The following is a description of a gene set: Preoperative radiotherapy has been widely used to improve local control of disease and to improve survival in the treatment of rectal cancer. However, the response to radiotherapy differs among individual tumors. Our objective here was to identify a set of discriminating genes that can be used for characterization and prediction of response to radiotherapy in rectal cancer. Fifty-two rectal cancer patients who underwent preoperative radiotherapy were studied. Biopsy specimens were obtained from rectal cancer before preoperative radiotherapy. Response to radiotherapy was determined by histopathologic examination of surgically resected specimens and classified as responders or nonresponders. By determining gene expression profiles using human U95Av2 Gene Chip, we identified 33 novel discriminating genes of which the expression differed significantly between responders and nonresponders. Using this gene set, we were able to establish a new model to predict response to radiotherapy in rectal cancer with an accuracy of 82.4%. The list of discriminating genes included growth factor, apoptosis, cell proliferation, signal transduction, or cell adhesion-related genes. Among 33 discriminating genes, apoptosis inducers (lumican, thrombospondin 2, and galectin-1) showed higher expression in responders whereas apoptosis inhibitors (cyclophilin 40 and glutathione peroxidase) showed higher expression in nonresponders. The present study suggested the possibility that gene expression profiling may be useful in predicting response to radiotherapy to establish an individualized tailored therapy for rectal cancer. Global expression profiles of responders and nonresponders may provide insights into the development of novel therapeutic targets. from publication Watanabe T, Komuro Y, Kiyomatsu T, Kanazawa T, Kazama Y, Tanaka J, Tanaka T, Yamamoto Y, Shirane M, Muto T, Nagawa H (PMID 16585155) Human Gene Set: WATANABE_RECTAL_CANCER_RADIOTHERAPY_RESPONSIVE_DN species: Homo sapiens Genes down-regulated in rectal cancer patients resistant to radiotherapy (non-responders) relative to the sensitive ones (responders)., and this is the list of marker genes: LYN, RHOBTB3, ARHGEF18, PRKY, ENSA (endosulfine alpha), CHUK, TBCC, FLNA, WSB1, ARID5B, POP5, TUBB2A, HSPE1, KRT20 (NCBI Gene Id 54474), HSPD1, COL3A1, MNT, NID2, KBTBD2, ATXN10, GRB10, CASP4, HBB, ARIH1, AGRN, BET1, SEC23A, DSG2, COL16A1, TYRO3, SCARB1, SNX2, ITGAV, CHD1, CCDC6, PSPHP1, ZNF117, PLPBP, KHSRP (KH-type splicing regulatory protein), NOP2, GLUD1, LGALS1, CAPG, AP3S1, SPR, POU2AF1, ABCE1, COL5A2, LUM, PPP2CA, RTN4, RCN2, RPS20, CCT6A (chaperonin containing TCP1 subunit 6A), ITGA1, RAC2, COL1A2, PIK3R3, ITGB1, HARS2 (NCBI Gene Id 23438), ZNF43, PPP1R12A, LGALS3, HMGXB4, PPP2R5C, MAP4, COL17A1, CFLAR, FXYD3, THBS2, MICB, SRP54, ANXA1, CUL1, PSPH, ATG12, TRAM1, PFN2, AHSA1, COL6A3, TMEM147, PCOLCE, ABR, PRKCI, GSK3B, ACTN1, PSMB6, GSTP1, KLF10, PSMA6, SIM2, PSMB5, RPP38